Given this list of marker genes ELF4, IGHG2, FOCAD, IGKC, IPO8, here is a description of the gene set: studied in species Homo sapiens Human Gene Set: HP_CHRONIC_GASTRITIS Chronic gastritis A chronic form of gastritis.